The following is a description of a gene set: Human Gene Set: LET_7C_3P Genes predicted to be targets of miRBase v22 microRNA hsa-let-7c-3p in miRDB v6.0 with MirTarget v4 prediction scores > 80 (high confidence targets). species: Homo sapiens from publication Chen Y, Wang X (PMID 31504780), and this is the list of marker genes: ETV5, MBD5, ZNF559-ZNF177, SCAF8, GK5, DMD, CELF5, RIC1, RMC1, UBL3, CASP3, ADNP, ZNF26, ZFAND5, SAT1, PIAS3, ADAM10, HERC1, HAPLN1, DNAH12, SIX1, MNT, DIDO1, VRK1, COL13A1, PPARGC1B, SCUBE3, PRKG2, PHF2, SOX4, BMI1, EMC8, CTDSPL2, ZNF10, ZNF638, POF1B, NPTN, GRID1, BCL7A (NCBI Gene Id 605), SLC10A7, RDX, ZMYND8, ZDHHC21, JMJD1C, MRPL11, ZNF451, REV1, SNRPD1, PDIA3, ANK3, AP3S1, AKIRIN1, NALCN, GNAS, NEDD1, GTPBP1, NID1, DCLK2 (doublecortin like kinase 2), ELAVL1, TAOK1, COX10, ZNF417, TMEM170B, SEC11A, ZC3H12B, TRRAP, CYB5R4, LRRC4, DCUN1D1, PTPRC, SEC24A, RNF169, TCF21, RAPGEFL1, GLRB, PPP2CA, SCAMP5, EBF1, TFAM, NEO1, RANBP9, SLAIN2, ZIC2, ADAM19, FABP3, MBTD1, MAML3, KLF4, LRP1B, STAG1, SUN1, KDM2B, HEPACAM2, SIPA1L2, DCTN2, TSC22D1, AUTS2, PDZD7, MAP3K2, GLCE, PLPPR1, FUBP1, CACNB4, UBE2W, PAK1IP1, LMTK2, FERMT2, NSD1, GRIP1 (glutamate receptor interacting protein 1), NFKBIA, AMMECR1L, HTR7, NUDT4, EP300, LRRC15, UAP1, FBXL3, DCUN1D3, UBR5, IRF6, FAXC, PDE10A, ZFHX4, MYBL1, TMEM106B, DYRK4, PTPRB, IWS1, RAD21, PRR12, GDNF, NCOA6, CLK2 (NCBI Gene Id 1196), CXCL3, RBBP6, CSMD2, AXIN1, GTF2H3, FGF7 (fibroblast growth factor 7), FLRT2 (fibronectin leucine rich transmembrane protein 2), ATAD2B, PGAP1, PPP2R5C, NUDT21, MED4, KSR2 (NCBI Gene Id 341537), RGPD3, PHLDA3, ARID4B, CADM2, SNRPB2, ABTB2, WWC1, NCAN, EBF2, FGF18, CUL2, ARFGEF2, GABRA5, ATP5MK, MRPS21, STAT5A, ISCU, LRCH1, MCTP1, CASD1, HMGN1, PGRMC2, RIMKLB (NCBI Gene Id 57494), FBXO21 (F-box protein 21), DOCK9, PLK1, KIF13A, BRD10, ABCC5, R3HDM1, DIP2C, ITGB1 (integrin subunit beta 1), SOX8, SUMO2, PARP14, MITF, CDC42SE2, GBX2, GOLGA1, HMGXB4, SUSD6, DNAJA2, FOXF1, NEDD4L, GLIS3, RIMS2, TCERG1L, RRP1B, MEMO1, YPEL2, ABI2, EIF5A2, PUS7, FAM83B, RASL11B, CEMIP2, KCNMA1, CYB5RL, UBE2E2 (ubiquitin conjugating enzyme E2 E2), RAB5C, PRKAA2, TAB3, EPS15L1, FAM76B, OTUD1, CDH11, TAF4, CLK4, ATRNL1, ADAMTSL1, CPEB2, CEP57L1, AMIGO2, KLF9 (NCBI Gene Id 687), SLC25A12, HMGCS1, CD55, TDO2, AFF4, FMNL3 (NCBI Gene Id 91010), ZNF268 (NCBI Gene Id 10795), GPM6A, RUNX2, EXOC4, CHL1, CEP170 (NCBI Gene Id 9859), AICDA, SETBP1, HS3ST5, WARS2, SPRY2, TOP2B, PTPRS, ITM2A, FHIP2A, GJA1, ST7, JAZF1, CMIP (c-Maf inducing protein), SLITRK4, CXCR4, SERPINE2, SOX6, PUM2, ANKRD12 (ankyrin repeat domain 12), SUMO3, ASCL1, EBF3, ELOVL7, GPR171, SLC6A6 (solute carrier family 6 member 6), RCAN2, WDFY3, IL17RD, KMT5B, ENKD1 (NCBI Gene Id 84080), CRMP1, BTBD7, GLI2, DNAJC8, SP3, AKAP1, ZNF674, DENND6A, TTLL5, TRIM63, RBM27, GNG12, TGFBRAP1, SEPTIN7, ZNF12, EPHA5, SMC6, JARID2, PPP3R1, SPAST, ARHGEF26, BMP2, SEC24D (SEC24 homolog D, COPII coat complex component), ZZEF1, FLI1, RAB40C, ARID1A, MBNL1 (NCBI Gene Id 9850), PPP1R8, UBE2G1, ZNF384 (NCBI Gene Id 404213), ATP1B3, RAP1B, NR4A3, NKTR, RARB (retinoic acid receptor beta), HOXB7, M6PR, ZNF219, KCNA2, TRIM43B, HOOK3 (hook microtubule tethering protein 3), MRTFB, MAP3K8, GPAM, E2F3, SOX2, RBL1, KHDRBS1, UBE2F, CCN3, DSCAML1, TCF7L2, NLK (NCBI Gene Id 51701), PSMG2, SMURF1, CSPG5, PLS3, TCEANC, RORA, DNM1L, DTWD1, CDH8, ZBTB44, GRIN3A, SLC24A2, CCL2, ARID4A, LRIG1, EXOSC10, PPP1R9A, COQ8A, RNF139, AKAP13, MEF2C, TANC1, TSPYL6, ERBIN, STAT2, ZMIZ1, MRPL49, KPNA4, RSL24D1, PARD6B, TRMT10B, LZTS2, SH2B3, GTPBP2, GABPB1, ATP6V1B2, SRSF4, CDK13, MOB1B, SIRT1, CDYL, DAB2, ZHX2, GNB4, CUL3, BMP7, MORF4L1, ZIC5, DFFB, NYAP2, SLC25A4 (solute carrier family 25 member 4), GCC2, SETD1A, SF3B1, CAMK2D, MECOM, TP63, PPP1R10, CHRM2 (cholinergic receptor muscarinic 2), BTAF1, CREBRF, GABRB2, PHIP, ADCY6, FZD1, PCLO, LMBR1, COMMD3-BMI1, RAB10, BCL11A, TNFRSF11B, ANTXR1, XRRA1, SLC20A2, RAB40B, NPAS3, SOX11, BACH2, SCYL1, TMEM248, DOCK4, ARHGAP11A, CITED2, L3MBTL3, CSNK1G3, AGTR1, HSPD1, CDKN1C (NCBI Gene Id 702), FBXL16 (F-box and leucine rich repeat protein 16), KMT2C, SINHCAF, NR2E1, PDK1 (NCBI Gene Id 5163), CLDN12, ZEB2 (NCBI Gene Id 9839), ATAD5, METTL3, EIF4B, KRAS, KNTC1, PEX3 (NCBI Gene Id 8504), PPP1CC, ZNF148, CTHRC1, C5orf22, MAP3K20, KLHDC1, PTGER3, HAT1, CYFIP2, KAT6A, HIVEP1, LRP12, FOXO1, FBXO38, ARID1B (NCBI Gene Id 645070), FMN1, GPHN, NR2F2, KMT2E, GRB10, KLHL14, LMNB2, BNC2, GNAI1, BPTF, SLITRK5, HIVEP2, HOXB2, SEC63, STXBP5L, GABBR2, NBEA, SERTAD2, MBNL2, RAB11FIP3, GNA13, CUX1, BRD4, NAP1L4, RAPGEF2, MEGF11, RPL29, RPS3, CLDN23, TMEM47, ARFGEF1, NAA16, ELL, SPATA6, PDE4A, MLLT10, TMEM170A, FOXJ3, E2F4, SCRN1, PPP3CA, ATP13A3, PRKCE, PRRC2C, SERTAD4, JADE2, GDF6, HMGCR, PHTF2, GPR6, ZNF703 (zinc finger protein 703), ZBTB33, ZFHX3, HS6ST2, TSHZ1, RXRA, PCDH7, USP12, SLC44A3, SP1, SLIT2, CMKLR2, MYT1L, GRHL2, PUM1, NAMPT, ZCCHC14, RRM2B, SUFU, ADAMTSL3, COLEC12, EIF4ENIF1, TAL1, EOMES, SIN3A, PDZRN4, GOLIM4, ALX1, C1QL1, P3H2, SNX14, CHD5, PPP1R12A, ZNF675, NECAB1, MT1X, KIF26A, ELOVL5, NR3C1, ELMOD2, PALD1, HNRNPU, CREB5, HECTD2, TRIO, SLC7A11, ICE2, THBD, SHOC2, MAP4K3, ZNF587, TLK1, GCLC, TRA2B, VCPIP1, PIM3, CSMD1, ATXN7, CSRNP3, PCGF5, STX16, ASH1L, ZNF704, SORBS2, UBE2K, BBX, ARHGAP44, RASSF3, CDYL2, DACH1 (NCBI Gene Id 1602), PPP6R3, GNPTAB, MIER3, RBBP5, LIX1L, POLR3E, HECW2, RERGL, COL4A6, CYRIB, SKIL, IBSP, SMARCC1, BAZ1A, C2orf74, OTOGL, SNX25 (NCBI Gene Id 83891), ZBTB7A, COQ10B, RALGPS1, ORC4, PPP1R14C, PDIA5, PAN3, FAM91A1